Given this list of marker genes PDE4B, CACNB4 (calcium voltage-gated channel auxiliary subunit beta 4), PDE8B, ADCY2, PTHLH, ADCY9, PDE4D, EPHA2, PDE4A, ADCY1, ADCY10, ADCY8, ADCY5 (adenylate cyclase 5), PDE7B, PTH, PDE7A, ADCY3, ADCY4, PDE10A, ADCY6, PDE8A, ADCY7, PDE4C, here is a description of the gene set: Human Gene Set: GOBP_CAMP_METABOLIC_PROCESS studied in species Homo sapiens The chemical reactions and pathways involving the nucleotide cAMP (cyclic AMP, adenosine 3',5'-cyclophosphate).